Given this list of marker genes RHBDL1, MXRA8, RCE1, XRCC2, LPAR2, PFKFB1, TLE5, SF3A3, PLCG2, SEPTIN2, DAZL, CLSTN1, LMO2, FAM149A, NDST1, TRAP1, VAMP1 (NCBI Gene Id 6843), CCDC22, HSPB3, LIPA, CEBPZ, COPS6, TCTA, CDIPT, SREBF2, CD74, CUL2, MEF2C, MKNK2, POLR3C, PMM1, NREP, CDA, MCM4 (minichromosome maintenance complex component 4), OPA1, RPS6KA1, PCCB, HLA-DRB4, PCDHA12, KDM4B, SIRPB1, NUTF2, VOPP1, LPL, LILRB5, SLC6A8, ACOT11 (acyl-CoA thioesterase 11), CDK11A, COX4I1, SASH3, VAMP8, SLC7A5, VAV1, RUVBL2, SPINK2, RANBP1, FOXN3, APPBP2, TRIM66, PIP4K2B, TPP1, UQCRH (ubiquinol-cytochrome c reductase hinge protein), ADGRL1, NBL1, PFDN5, TTC1, CD59, NEK2 (NIMA related kinase 2), PCDHB11, SVIL, MYBPC2, C1orf216, FAM32A, NPM1, PSMD1, KCTD12, PRPF8, GARS1, TRAF5, ADD1, AP2S1, ACRV1, CAMK1, AP3M2, NDUFV1, PTPN7, PPP2R5E, CYB5R1, PACS2, PTPRD, PC, GDI2, ADO, RPL5, PLOD3, QPRT, SPC25, THUMPD1, MXI1, GIT2, UBXN1, DNAJC13, OLFML2B, TBC1D2B, FCN1, CD72, SDC1, CRYBB1, DHX38, GFUS, CBX7, DUSP3, CALD1, ATXN2, DPM2, CDK4, CYP2B7P, RPS6KB2 (ribosomal protein S6 kinase B2), GPC3, GBA1 (NCBI Gene Id 82008), URB2, MAGI1, CMTR1, LINC00847, ARRB2, PPP2R5A, CUX1, MRPL40, PLRG1, ASMTL, API5, ZYX, KIF13B, ZNHIT1, COMMD4, ENOSF1, SERTAD2, ENTPD6, MLF2, SQSTM1, BANF1, AHCYL1, NTNG1, TRAK2, PART1, ZNF148, LYRM9, RPS6, SLC4A8, SSBP1, MISP, NDRG2, BRD3, CHERP, NAP1L4, ALDH1B1, LAMTOR5, S100A13, SPINT1, EEF1G (eukaryotic translation elongation factor 1 gamma), QKI (QKI, KH domain containing RNA binding), GPNMB, CTSK, HIC2, NUP214, DCP2, NUP188 (nucleoporin 188), ZNF629, VAMP3, SEMA7A, LTA4H, ANAPC5, MIOS, CLN3, CDR2L, VAMP2, FARSA, MAK16, ARF5, ORC4, GABARAP, DNAH7, GLIPR1, RPS4X, DAZAP2, PPBPP2, ESD, CYP2C8, ARTN, SLC2A5, SHC1, SLC4A7, FMO6P, SPECC1L, LAMB2, FRAT2 (NCBI Gene Id 93368), NEDD8, TNNC2, here is a description of the gene set: species: Homo sapiens from publication Chaussabel D, Semnani RT, McDowell MA, Sacks D, Sher A, Nutman TB (PMID 12663451) Human Gene Set: GSE360_CTRL_VS_M_TUBERCULOSIS_MAC_UP Genes up-regulated in comparison of macrophages versus macrophages exposed to M. tuberculosis. Monocyte-derived dendritic cells (DC) and macrophages (MΦ) generated in vitro from the same individual blood donors were exposed to five different pathogens, and gene expression profiles were assessed by microarray analysis. Responses to Mycobacterium tuberculosis and to phylogenetically distinct protozoan (Leishmania major, L. donovani, Toxoplasma gondii) and helminth (Brugia malayi) parasites were examined, each of which produces chronic infections in humans yet vary considerably in the nature of the immune responses they trigger.